The following is a description of a gene set: Human Gene Set: REACTOME_MITOTIC_G1_PHASE_AND_G1_S_TRANSITION studied in species Homo sapiens Mitotic G1 phase and G1/S transition, and this is the list of marker genes: PPP2CA, CCNB1, CDKN1C, POLE4, CDK2, RPS27A, PSMD14, PSMD7, PSMD12, UBC, SKP1, UBA52, POLA2, PSMB2, SEM1, CDC25A, CDK6, CABLES1, POLE3, PSMB1, MCM6, MYC, CUL1, MCM4, CKS1B, CDC7, PSMC6 (proteasome 26S subunit, ATPase 6), PPP2R1B, MCM7, PSMD13, LIN52, DBF4, RBL2, CCND1, PSMC3, JAK2, RPA3, RBL1, MAX, PSMD8, TK1, AKT1, HDAC1, PPP2R1A, RRM2, CDKN1B, ORC6, CDKN1A, PSMA1, UBB, PCNA, PSMA4 (NCBI Gene Id 5685), PSMA2, PSMD11, PSMB3, CDC45, PPP2CB, CDKN2A, MCM10 (NCBI Gene Id 55388), RBBP4, MCM5, ORC3, PSMB7, RPA1, WEE1, LIN9, RPA4, PSMA7, PSMC2, POLE2, CDK4, CCNE1, AKT2, CCND2, LIN37, LIN54, MCM2, ABL1, RPA2, PSMC5, E2F6, ADRM1, PSMD2, CDKN2C, CDT1, E2F3 (NCBI Gene Id 1871), CDK7, POLE, SKP2, TYMS, CCNA2, RB1, PPP2R2A, CCNE2, PSMC4, PRIM1, PSMB6, GMNN, ORC1, CDK1 (cyclin dependent kinase 1), AKT3, PPP2R3B, TFDP1, MCM8, E2F2, CDC6, PSMA5, TFDP2, DYRK1A, POLA1, SRC, PSMA3, DHFR (NCBI Gene Id 203373), ORC5, E2F5, CDKN2B, E2F4, CCND3, PSMD3, E2F1, CCNH, FBXO5, PSMD1, PTK6, MNAT1 (MNAT1 component of CDK activating kinase), ORC2, CDKN2D, CCNA1, PRIM2, PSMB5, MYBL2 (MYB proto-oncogene like 2), PSMA6, MCM3, PSMB4, PSMC1, ORC4, LYN, PSMD6, TOP2A